The following is a description of a gene set: Reactome Pathway: Defective AHCY causes HMAHCHD studied in species Homo sapiens Adenosylhomocysteinase (AHCY) is a tetrameric, NAD+-bound, cytosolic protein that regulates all adenosylmethionine (AdoMet) dependent transmethylations by hydrolysing the feedback inhibitor adenosylhomocysteine (AdoHcy) to homocysteine (HCYS) and adenosine (Ade-Rib). Defects in AHCY cause Hypermethioninemia with S-adenosylhomocysteine hydrolase deficiency (HMAHCHD; MIM:613752), a metabolic disorder characterised by hypermethioninemia associated with failure to thrive, psychomotor retardation, facial dysmorphism with abnormal hair and teeth and myocardiopathy. part of: Metabolic disorders of biological oxidation enzymes, and this is the list of marker genes: AHCY